The following is a description of a gene set: The process in which a precursor cell type acquires the specialized features of a myeloid progenitor cell. Myeloid progenitor cells include progenitor cells for any of the myeloid lineages. Mouse Gene Set: GOBP_MYELOID_PROGENITOR_CELL_DIFFERENTIATION studied in species Mus musculus, and this is the list of marker genes: Braf, Kit, Tet2, Runx1, Dpf2, Mlf1, Spi1, Flt3, Hmgb1 (NCBI Gene Id 15289), Sp3, Ankle1, Slc37a4, Jam3, Sp1